Given this list of marker genes Ihh, Arx, Cdh13, Cdkn1a, Epha2, Tnfaip3, Foxe3, Kit, Klk8, Grn, Thbs1 (NCBI Gene Id 21825), Gata6, Azin1, Mdk, Tnf, Ceacam2, Plau, Ang6 (angiogenin, ribonuclease A family, member 6), Aldh1a2, Foxp1, Prok2, Sdr16c5, Fgfr2 (fibroblast growth factor receptor 2), Stat6, Errfi1, Emc10, Acvrl1, Sidt2, Nrarp, Igf2, Muc16, Six1, Kdr, Tgfb1 (transforming growth factor, beta 1), Maged1, Erbb3, Col4a3, Kdf1, Cnmd, Vdr, Ghsr, Sfrp2, Loxl2, Notch2, Scarb1 (NCBI Gene Id 52288), Glul, Tbx2, Ccl24, Npm1, Ccnd1, Trp63, Stat5a, Smo, Tbx18, Cdk6, Tnfsf11, Pdx1, Atp5if1 (ATP synthase inhibitory factor subunit 1), Ptprn, Fshr, Il12a, Ccn3, Ccr3, Bcl11b, Tsc2, Apln, Pdpk1, Dlx5, Dicer1, Ptch1, Phb2, Ift57, Nfkbiz, Esr1, Mir124a-1hg, Fgf18, Pik3cb, Rbpj, Wnt5a, Plxnb3, Nkx6-1, Tbx1, Cxcl12, Xbp1, Map2k2, Serpinf1, Nme2, Fgf7, Fa2h, Mst1, Rasgrf1, Gdf2, Fmc1, Col8a1, Pdcl3, Hmox1, BC004004, Osr2, Nfatc1 (nuclear factor of activated T cells, cytoplasmic, calcineurin dependent 1), Wdr13, Ccl2, Fgf10 (NCBI Gene Id 14165), Gpr15lg, Intu, Fap, Ggcx, Nkx2-3, Cdk4, Angptl8, Dlx6, Apoe, Ngfr, Tcf7l2, Bmp6, Mef2c, Birc5, Alms1, Mki67, Lep (NCBI Gene Id 16846), Fst (follistatin), Tmigd1, Dbh (NCBI Gene Id 13166), Fgl1, Hyal1, Wdr77, S2bpcox16, Gpx1, Bnc1, Ang, Rida, Cav1, Zfp580, Wnt16, Esrp2, Uhrf1, Osr1, Hgf, Crnn, Stat1, Gdf5, Apoa1, Ctsl, Polr3g, Ctnnb1, Ar, Aqp11, Frs2, Il17a, Hes5, Agtr1b, Ift88, Nkx2-5, Fam3c, St8sia1, Cyp7b1, Acvr2a, Slurp1, Pura, Gli1, Atp7a, Dach1, Lipa, Jcad, Egf, Vip (vasoactive intestinal polypeptide), Ovol1, Gja1, Ang4, Areg, Eppk1, Marveld3, Wdr48, Nkx3-1, Cdkn1b, Synj2bp, Ift52, Cxadr, Ncstn, Hey1, Bglap, Pkhd1, Rreb1, Pgr, Aggf1, Myc, Dab2, Zfp36l1, Zfas1, Gpbar1, Nkx2-6, Mmp12 (NCBI Gene Id 17381), Sgpp2, Prdm1, Ptn, Rptor, Eng, Esr2, Col8a2, Aplnr, Serpinb1c, Wnt7a, Nr1d1, Nupr1, Chuk, Sirt1, Apela, Ift74, Hmgn1, Ptprv (NCBI Gene Id 64447), Hnf1b, Pax2, Serpinb5, Psen1, Prkca, Fgf2, Serpinb1b, Stat3, Rb1, Map2k1, Yap1, Vash2, Gpc3, Gkn3, Slurp2, Tgfbr1, Smad3 (NCBI Gene Id 17127), Btrc, Egfl7, Ghrl, Ager, Ppp1r16b, Pten, Prkx, Prox1, Esrp1, Mmp14, Lrg1, Sirt6, B4galt1, Kdm5b, Wnt3a, Vegfc, Thbs4, Runx3, Dlg1, Hmgb2, Cxcr3, Dsc1, Ccl11, Lrp6, Nog, Hmgb1, Bmp4, Hlx, Nkx2-9, Twist1, Pygo2, Bmyc, Tacstd2, Prl, Rgcc, Hspg2, Bcl2l2, Reg3a, BC028528, Pdcd10, Dll4, Eya1, Id2, Hsf1, Extl3, Atf2, Stk3, Il6, Agap2, Vhl, Zeb1, Ang5, Tie1, Il18, Fut2, Bmpr1a, Wnt10b, Gli2, Nr4a1, Cd109, Bcl2l1, Aimp1, Igfbp3, Sema5a, Eaf2, Zfp36, Xdh, Arg1, Bmp5, Nr2f2, Nfib, Cldn18 (claudin 18), Plcg1, Ccl5, Mcc, Ceacam1 (CEA cell adhesion molecule 1), Cyba, C5ar1, Ednrb, Gata2, Zeb2, Celf1, Hdac6, Has2, Gata3, Prok1, Mydgf, Bmpr2, Sulf1, Itgb3, Ncf1 (NCBI Gene Id 17969), Akt3, Ednra, Nod2, Atoh8, Srsf6, Pparg, Irf6, Prkd1, B2m, Bax, Wfdc1, Rgn, Deaf1, Tacr1, Fgf9, Gas1, Drd2, Flcn, Nme1, Isl1, Pex2, Six4, Wnt2, Mtss1, Atp5f1a, Pdcd6, Mapk1, Kif3a, Erbb4, Prkdc, Map2k5, Pax6, Fzd7, Itgb3bp, Akt1, Raf1, Mmrn2, Flt4, Tgm1, Ccnd2, Igfbp5, Cebpb, Id1, Ereg, Rap1gap, Lgr4, Iqgap3, Pik3cd, Phox2b, Ptprm, Adam17, Sulf2, Robo1, Hpn, Etv4, Itga4, Ift122, Adk, Scg2, Ecm1, F3, Fermt1, Hoxa5, Lims2, Nras, Vstm4, Shh, Bak1, Ifng, Hmga2, Egr3, Adora2b, Tgfb3, Egfr, Agtr1a, Suz12, Sox9, Vegfb, Krt2, Apc, Cd34, Ern1, Nrbp1, Irs2, Erbb2 (NCBI Gene Id 13866), Cdkn2a, Sp1, Htra1, Serpinb1a, Jun, Cdkn2b, Dlk1, Lama5, Twist2, Slc39a9, Dab2ip, Tgfb2, Nr4a3, Pold4, Stxbp4, Fgf1, Ift80, Nodal, Phip, Hras, Tnmd, Bid, Pdgfb, Rictor, Runx2, Igf1, Nf1, Tfap2c, A4gnt, Tinf2, Bad, Men1, Scn5a, Dysf, Med1, Fut1 (NCBI Gene Id 14343), Cdkn1c, Sparc, Btk, Sox2, Mta3, Bmper, Snai2, Il10, Enpep, Htr2b, Cflar, Stk4, Zfp703, Nppb, Ovol2, Rian, Klf9, Fgfr3, Stk11, Odam, Cask, Apoh, Efnb2 (NCBI Gene Id 13642), Rtn4, Cdc42, Tek, Fgfbp1, Vash1, Hes1, Fgfr1, Ift172, Ppard, Pgf, Hmx2, Alox5, Ptprk, Tcf19, Trim24, Cdh1, Krit1, Bglap2, Cdh3 (cadherin 3), Tgfbr3, Nlrc3, Mtor, Reg3g, Or51e2, Mir205, Tgfa, Hrh3, Rps6ka1, Fabp7, Lims1, Flt1, Dusp10, Ang2, Krt4, Saal1, Sav1, Foxp2, Thap1, Vegfa, Itgb1bp1, Col18a1, Prkd2, Clec12b, Itpr1, Jag1, Mycn, Ccl26, Sfrp1, Pla2g2a, Cav2, Igfbp4, Brca2, Reg1, Lgr5, Il12b (interleukin 12b), Ccl12, Sox11, Cldn1, Cdc73, Sfn, Jaml, Fshb, Notch1, Epgn, Cdc25a, Cpb2, here is a description of the gene set: Mouse Gene Set: GOBP_EPITHELIAL_CELL_PROLIFERATION species: Mus musculus The multiplication or reproduction of epithelial cells, resulting in the expansion of a cell population. Epithelial cells make up the epithelium, the covering of internal and external surfaces of the body, including the lining of vessels and other small cavities. It consists of cells joined by small amounts of cementing substances.